The following is a description of a gene set: species: Homo sapiens Human Gene Set: MIR548AV_3P Genes predicted to be targets of miRBase v22 microRNA hsa-miR-548av-3p in miRDB v6.0 with MirTarget v4 prediction scores > 80 (high confidence targets). from publication Chen Y, Wang X (PMID 31504780), and this is the list of marker genes: THBS1, CCAR1, APLN, MAGI2, SLC45A4, RANBP6, MAP4K4, NR4A3, SCG5, ATF1, ATP9A, CTDSPL2, TET2, KGD4, CTNND2, MTSS1, YWHAG, CDK19, NR4A2, RIMS2, HMGN3, SHROOM4, DNAJB14, ADSS2, PAIP1, TSC22D2, PPTC7, SLC39A12, STT3A, TTPA, KBTBD8, SLC16A7, PALM2AKAP2, ETV1, CBLL1, HOXB7, NUP188, TRIP12, ZFP36L1, KIAA0319, TDG, CKAP2, NCOA2, SLMAP, MSRB3, TENM1, ALG13, BICRAL, PCGF5, GLCCI1, DLC1, SPRED1, GMFB, NAA50, MIA2, MSH3, CCDC40, CAMTA1, SLITRK3, ZEB1, EIF4G3, WDFY1, BRWD1, SP100, TRAPPC11, DDX3X, AMHR2, SEMA6B, LGR4, ESRRG, ZFAND6, AFF2, COL1A1, PRKAR2B, PCNA (NCBI Gene Id 5111), MIER3, ATL2, HNRNPU, FAM118B, INO80D, FAM169A, YTHDF2, KRCC1, KLF5, MAGEB16, CASP2, URI1, LINGO3, BAG4, B4GALT4, TUBGCP2, PBX2 (PBX homeobox 2), SH3KBP1, ARL6IP1, CLOCK (clock circadian regulator), ALS2, GXYLT1, SEMA3C, FOXJ3, DTNA, DHX15, SH3GL2, PMS1, ADGRB3, CLPB, TSHZ1, FUBP3, ATP8A1, SFPQ, VDAC1, HECTD2, MAPK8IP1, FOXO3, TOX, TNPO1, SCAI, SVIL, PCGF3, ATP11C, GNA13, SYNCRIP, PIGK (phosphatidylinositol glycan anchor biosynthesis class K), PTEN, EIF3J, GKAP1, PCGF2, SERP1, FAM168B, TOR1AIP2, GID4, CLEC7A, DMTF1, NLGN4X, MYEF2, ARPP19, E2F7, KDM4C, NRBF2, STMN2, MED17, CPSF6 (cleavage and polyadenylation specific factor 6), CNTN4, CDKL4, OGG1, TRIM2, MYO5A, CDC42SE2, IKZF5, CREBRF, ADAM10, LBR, RPL36A, PPM1A, TSG101, TMEM47, PRP4K, GLS, TPBG, IQUB, KLF7, WNT3, SRSF8 (NCBI Gene Id 115898), ATG4C, CCT6B, SV2C, DCLK3 (NCBI Gene Id 85443), TBP, URB2, SIAE, DDX46, RPAIN, PHIP, ADARB2, NOL4, EEF1A1, AASDHPPT, SET